Given this list of marker genes VIPR1, CACNA2D4, XPC, THEMIS, IMPACT, TLE4, KLF6, FOXO3, ST3GAL6, PID1, BAG3, SYF2, FAM219B, MEF2D, RHBDL3, ADTRP, CFLAR, PRSS12, TDRP, CFL2, KCNK6, VKORC1, MYH10, FASLG, LFNG, SP6, PIK3R1, BEST1, CYP2D6, SCML4, PHF3 (PHD finger protein 3), PPM1B, ZNF652, PEX26, MEIS3, SUCO, BIRC2, PIK3R5, SMAD1, DDR1, RPS7, KIF5C, CYTIP, TSC22D3, SMAD4, TRH, PROS1, IFITM10, CYLD, ZBTB4, SLC13A1, ZMYND11, PAG1, KIAA0040, NDNF, BCL9L, FOXP1, HLA-A, CHD3, MICALL1, TRAT1, NEUROG3, LCE3B, PACC1, ABHD14A, RAC3, ZNF281, FLACC1, CYP4V2, PARP16, B4GALT1, CEBPZ, ZFR2, GPR68, DNAJB2 (DnaJ heat shock protein family (Hsp40) member B2), KIAA0930, FILIP1L, PCMTD1, ZNF263, ARHGAP5, DTX1, GPRASP1, CD226, PIK3IP1, ARL4C, PRKD3, ACVR1B, CHIC1, ARID1A (AT-rich interaction domain 1A), SLC16A8, SGMS1, LRRN3, GPR34, GALNT10, MUC5B, GAL3ST1, RPS16, OSR1, ATP2B1, KCNC2, ELF2, DNAI4, FSTL5, TENT5A, MAP3K9, BCL11B, BTG3, EYA2, PXYLP1, TMEM141, MSL2, UQCC5, CARD6, TRIM56, PDE8A, LRIG1, DDX5, TMEM127, FBXL12, EARS2, GPANK1, SGK1, PIP5K1B, ERG, QPCT, FBXO10, C14orf180, TMEM154, SKI, DAPL1, FHIP1B, RPL12, GPATCH4, HSPA12A, CREBRF, FAM3C, BEX2, EIF4A2, RARG, ICE1, SNTB1, TSR1, RRM2B, HEATR6, SIT1, APP (NCBI Gene Id 351), IL7R, SHLD1, TFAP4, CBX4, PITX1, RPS29, ACIN1, ST8SIA6, ATXN1L, C8orf58, RHBDD2, FRS3, LYPD6B, DTX4, ABCB1, LRRC23, ACBD3, CRIM1, SLC9A9, PCTP, ENAM, LDLR, BTG1, C21orf91, FTSJ3, RFLNB, ZSCAN26, PGLYRP2, EEIG1, RNASE3, MACROD1, PDE3A, GPR65, IL20RA (interleukin 20 receptor subunit alpha), CDC42EP3, CD72, DYRK2, H2AC25 (NCBI Gene Id 92815), PLEKHH3, MAPK12 (mitogen-activated protein kinase 12), EPAS1, PPARGC1B, OTUD1, METTL23, AMIGO2, PPM1H, HEPACAM2, ALKBH4, HEXA, NR1D2, CKLF, SLC39A5, PADI2, BCL7A, here is a description of the gene set: studied in species Homo sapiens Human Gene Set: GSE39110_UNTREATED_VS_IL2_TREATED_CD8_TCELL_DAY3_POST_IMMUNIZATION_UP from publication Castro I, Dee MJ, Malek TR (PMID 23018461) Genes up-regulated in CD8 T cells 3 days after immunization: control versus IL2 treatment. Much is known concerning the cellular and molecular basis for CD8+ T memory immune responses. Nevertheless, conditions that selectively support memory generation have remained elusive. Here we show that an immunization regimen that delivers TCR signals through a defined antigenic peptide, inflammatory signals through LPS, and growth and differentiation signals through the IL-2R initially favors antigen-specific CD8+ T cells to rapidly and substantially develop into tissue-residing T effector-memory cells by TCR transgenic OVA-specific OT-I CD8+ T cells. Amplified CD8+ T memory development depends upon a critical frequency of antigen-specific T cells and direct responsiveness to IL-2. A homologous prime-boost immunization protocol with transiently enhanced IL-2R signaling in normal mice led to persistent polyclonal antigen-specific CD8+ T cells that supported protective immunity to Listeria monocytogenes. These results identify a general approach for amplified T memory development that may be useful to optimize vaccines aimed at generating robust cell-mediated immunity. Gene expression analysis was performed for OT-I T cells on day 3 and day 5 after activation with ovalbumin and LPS in vivo with and without treatment with IL-2 using an agonists IL-2/anti-IL-2 complexes (IL2/Jes-6.1)